The following is a description of a gene set: Juvenile cataract Human Gene Set: HP_JUVENILE_CATARACT species: Homo sapiens A type of cataract that is not apparent at birth but that arises in childhood or adolescence., and this is the list of marker genes: MECP2, CYP27A1, ADNP, SPTBN1, RDH11, RECQL4, FAR1, TGM3, NACC1, ANAPC1, LEMD2